Given this list of marker genes MTM1, PIK3C2A, MTMR4, PIKFYVE, PIK3C3, MTMR7, MTMR2, FIG4, PIK3R4, VAC14, MTMR9, here is a description of the gene set: part of: PI Metabolism At the late endosome membrane, the primary event is the dephosphorylation of the phosphoinositide phosphatidylinositol 3,5-bisphosphate (PI(3,5)P2) to phosphatidylinositol 3-phosphate (PI3P) and phosphatidylinositol 5-phosphate (PI5P). species: Homo sapiens Reactome Pathway: Synthesis of PIPs at the late endosome membrane